The following is a description of a gene set: from publication Chen Y, Wang X (PMID 31504780) species: Mus musculus Genes predicted to be targets of miRBase v22 microRNA mmu_miR_7028_3p in miRDB v6.0 with MirTarget v4 prediction scores > 80 (high confidence targets). Mouse Gene Set: MIR_7028_3P, and this is the list of marker genes: Ric3, Arpc5l, Eif4e, Slc4a10, Skint3, Oprk1 (NCBI Gene Id 18388), Mex3a, Zfp704, Ndufaf5, Fam81a, Zfp109, Mapt (NCBI Gene Id 17762), Pou2af2, Neto1, Galt, Ralbp1, Mbd1, Rnd3, Ehd4, Krtap16-3, Epha7, Lipt1, Clasp2, Cd200r3, Stradb, Sh3tc2, Sltm, Prkg1, Msr1, Ttll7, Zfp652, Ctsm, Kdelr1, F11r, Zfp462 (NCBI Gene Id 242466), Rpl7l1, Tcp1, Syn1, B4galt6, Sfxn4, Ubxn7, Zfp934, Wsb1, Fxr1, Rwdd4a, Sertad2, Mfsd4b5, Thrb, Rnase10, Dgkb, Tln2, Erc1, Tasor, Lrrc15, Prkcq, Pbdc1, Lrp8, Rnmt, Cdh20 (cadherin 20), Mesp2, Cdkn1b, Taf12, Itgb3, Zfp984, Mat2a, Ubn2, Lmna, Phactr2, Rad54b, Tmem30c, Ddx6, Col19a1, Znrf1, Ccdc68, Naa50, Tmem132b (transmembrane protein 132B), Bhlhe40, Metap1, Zfp268, Dennd2a, Mgat3, Ifnar1 (NCBI Gene Id 15975), Zmynd8, Chchd3, Cfap97, Zfp987, Ddx4, Arhgap20, Ttll4, Rab39, Phactr3, Secisbp2l, Galnt2, Adgrf5, Tfdp2, Kars1, Klhl11, D3Ertd751e, Dag1, Grin2b, Hspd1, Adora2a, Mtus2, Olfml2b, Spag11b, Osbpl3, Chek1, Npas2, Nab1, Tmed8, Pif1, Mapre2, Cyfip2, Cramp1, Ankrd34b, Zfp780b, Zfyve26, Sdc3, Hivep3, Morc2a, Myoz3, Ccdc82, Wbp1l, Pcsk2, Tmem178b, Ildr2